Given this list of marker genes Notch4, Nfatc3, Edn1, Ephb4, Ptger4, Mdk, Efnb2, Rtn4, Akt3, Notch1, here is a description of the gene set: studied in species Mus musculus Any process that modulates the frequency, rate or extent of artery morphogenesis. Mouse Gene Set: GOBP_REGULATION_OF_ARTERY_MORPHOGENESIS